Given this list of marker genes DIO3, GNAT1, GNAT2, RPGRIP1, CABP4, NTRK2, SOX8, SAMD7, PDE6C, NDP, THRB, RORB (RAR related orphan receptor B), HCN1, PROM1, DSCAM, SAMD11, IHH, BBS4, ROM1, USH1C, CRB2, STAT3, SDK2, CNTF, NAGLU, RPGRIP1L, NRL, TTC8, BBS10, THY1, SOX9, RP1 (RP1 axonemal microtubule associated), NOTCH1, here is a description of the gene set: studied in species Homo sapiens The process in which a relatively unspecialized cell acquires the specialized features of a photoreceptor cell in a camera-type eye. Human Gene Set: GOBP_CAMERA_TYPE_EYE_PHOTORECEPTOR_CELL_DIFFERENTIATION